Given this list of marker genes Smarca1, Nfrkb, Pld5, Psd4, Scai, Dcaf17, Smarcc1, Runx1t1, Kcnmb2, G2e3, Acyp1, Klhdc2, Rbm27 (RNA binding motif protein 27), Tmem236, Tshz3, Cpsf2, Ifi213, Rnf130, Zscan26, Rpl39 (NCBI Gene Id 67248), P2rx3, Trim9, Ube2b, Prdm1, Uxt, Frrs1l, Vps26b, Cd160, Sh3pxd2a, Nr2c2, Galnt1, Hmcn1, 6030458C11Rik, Zbtb41, Fgf13 (NCBI Gene Id 14168), Pbx1, Pi4k2a, Psen2, Bbs4, here is a description of the gene set: species: Mus musculus Mouse Gene Set: MIR_152_5P Genes predicted to be targets of miRBase v22 microRNA mmu_miR_152_5p in miRDB v6.0 with MirTarget v4 prediction scores > 80 (high confidence targets). from publication Chen Y, Wang X (PMID 31504780)